Given this list of marker genes SCNN1G, ADCY1, ZNF491, TAS2R7, MIR3936HG, CFAP157, BMP4, DEFB124, DEFT1P (defensin theta 1, pseudogene), FLRT3 (NCBI Gene Id 23767), MME, SDK2, NMU, OLFM1, GALNT14, TSSK3, STT3A, RPS8, CA7, STH, LINC02520, HORMAD2, CASC11, GPATCH11, KRTAP9-8 (keratin associated protein 9-8), RPL10L, FBLN1, MBOAT2, RPL38, IL6-AS1, VWA1, CHRM1, FBXO10, GPR4, YWHAEP7, FAM78B, TPT1P8, MEP1B, CHAT, OR52A1, SLC25A48, PAEP, MAP3K15, FAM43B, TAC3, LPAL2 (lipoprotein(a) like 2 (pseudogene)), RIMS2, MCHR2, PANX2, MAP3K9, SYT13, CD300LG, NEBL, UPK2, SLC5A4, SNORD104, CC2D2A, LINC00626, MACROH2A2, FGF23, CFAP70, MS4A1, SORBS2, KRT33B, UCN3, TNFSF18, TP53AIP1, ABRACL, GRM5, INSL3, MYRF-AS1, MAGEA5P, EVC, EEF1B2, ACTRT2, LCMT1-AS2, PHACTR2-AS1, TPRXL, PTH2, ZNF135, BHLHE22-AS1, DNAH14, OR51B5, CNIH3, DAP3, KIF12, GLB1L2, PLA2G10, ZKSCAN3, LEMD1, HOXC12, PAX9, ARC, PRDM16, ACOD1, KRT23, RBP4, MYPN, LRRN2 (NCBI Gene Id 353178), ALOXE3, ACP4, PMS2P11, SMTNL2, GPR137, KCNJ11, MMP2 (NCBI Gene Id 4313), LINC00589, AHDC1 (AT-hook DNA binding motif containing 1), MOBP, BPIFA4P (NCBI Gene Id 317716), SLC17A1, CXCR1, LINC01592, NXPE4, PRSS2, NECAB2, CHST3, GALNT18, NR2E1, VASH2, LINC00905, DNAJC5G, ATP13A3-DT, AZGP1P1, RPL3L, LINC01686, LINC00656, LRRTM1, FSHR, PRR36, ENSG00000282375, ILVBL, TLL1, USP44, MMP28, PCDHAC2, COX4I1, LINC00642, CCDC116, CXCL12, CBX2, C5orf46, PLEKHG6, PHOX2A (NCBI Gene Id 8064), EFCAB5, ALDH1L1, ENSG00000235143, IL6, PANK4, RASIP1, PI3, AQP4-AS1 (NCBI Gene Id 147429), KCNK15, LRRC52-AS1, FAM53A, DZIP1, OR6A2, CLLU1, MAT1A (methionine adenosyltransferase 1A), ATPSCKMT, DAB1, FOXB1, CCL24, RAB26, GDPD2, KSR2, TMEM235, LINC00929, CC2D2B, ITGA10 (NCBI Gene Id 8515), GPR50, CD24, FAM81A, H4C1, EEF1AKMT1, ST3GAL3, PIERCE2, MFAP2, GOLT1A, HOXB13, ADAD1, PTTG2, LINC02523 (long intergenic non-protein coding RNA 2523), EIF3H, FBL, MKRN7P, UCP1, KCNE1, CNTNAP3, CIBAR1-DT, MIR124-1HG, SAMD13, here is a description of the gene set: Human Gene Set: GSE13485_DAY7_VS_DAY21_YF17D_VACCINE_PBMC_DN from publication Querec TD, Akondy RS, Lee EK, Cao W, Nakaya HI, Teuwen D, Pirani A, Gernert K, Deng J, Marzolf B, Kennedy K, Wu H, Bennouna S, Oluoch H, Miller J, Vencio RZ, Mulligan M, Aderem A, Ahmed R, Pulendran B (PMID 19029902) The immune responses generated by YF-17D by profiling genes in 25 vaccine recipients were accessed at days 1, 3, 7, and 21 post-vaccination compared to pre-vaccination in PBMCs. The immune responses generated by YF-17D by profiling genes in 25 vaccine recipients were accessed at days 1, 3, 7, and 21 post-vaccination compared to pre-vaccination in PBMCs. species: Homo sapiens Genes down-regulated in comparison of unstimulated peripheral blood mononuclear cells (PBMC) 7 days after stimulation with YF17D vaccine versus PBMC 21 days after the stimulation.